Given this list of marker genes Xpc, Cul4a, Cops6, Ubb, Tfpt, Nfrkb, Yy1, Cul4b, Rps27a (ribosomal protein S27A), Ddb1, Ino80b, Ino80c, here is a description of the gene set: part of: Global Genome Nucleotide Excision Repair (GG-NER) studied in species Mus musculus This event has been computationally inferred from an event that has been demonstrated in another species.<p>The inference is based on the homology mapping from PANTHER. Briefly, reactions for which all involved PhysicalEntities (in input, output and catalyst) have a mapped orthologue/paralogue (for complexes at least 75% of components must have a mapping) are inferred to the other species. electronically inferred by orthology from the curated human pathway Reactome Pathway: DNA Damage Recognition in GG-NER